The following is a description of a gene set: Human Gene Set: GSE14769_UNSTIM_VS_40MIN_LPS_BMDM_DN from publication Litvak V, Ramsey SA, Rust AG, Zak DE, Kennedy KA, Lampano AE, Nykter M, Shmulevich I, Aderem A (PMID 19270711) Genes down-regulated in comparison of unstimulated macrophage cells versus macrophage cells stimulated with LPS (TLR4 agonist) for 40 min. studied in species Homo sapiens The innate immune system is a two-edged sword; it is absolutely required for host defense against infection, but if left uncontrolled can trigger a plethora of inflammatory diseases. Here we used systems biology approaches to predict and validate a gene regulatory network involving a dynamic interplay between the transcription factors NF-κB, C/EBPδ, and ATF3 that controls inflammatory responses. We mathematically modeled transcriptional regulation of Il6 and Cebpd genes and experimentally validated the prediction that the combination of an initiator (NF-κB), an amplifier (C/EBPδ) and an attenuator (ATF3) forms a regulatory circuit that discriminates between transient and persistent Toll-like receptor 4-induced signals. Our results suggest a mechanism that enables the innate immune system to detect the duration of infection and to respond appropriately., and this is the list of marker genes: CTTNBP2NL, PIBF1, BIRC3, RNF19B, SLC4A1AP, SGK1, IFRD1, NSMCE1-DT, VEGFA, EXOC3L4, SYCE3, CSNK1E, ATPAF1, UBC, TOB1, ZFP62, SETDB2, TLR2, IL10RA, ZC3H12C, RND3, ATF3, MALT1, FILIP1L, LHCGR, DUSP1, IRF1, RMC1, TASL, TGIF1, RRAGA, CDC42EP2, KDM6B, JUNB, SLC38A2, SPATS2, MEX3C, RCAN1, PTPN5, NFKBIB, ARFGAP3, HAUS7, USP18, GPD1L, TRAF1, IER5, SQSTM1, EGR1, L3MBTL3, GK5, JUN, IL11RA, CD14, GAS8, PLK2, SDC4, STK35, ARID5A, CFLAR, KLKB1 (kallikrein B1), MMP13, CXCL2, PIM1, PHLPP2, NFKBID, MYC, PTGER4, FEM1C (NCBI Gene Id 84463), CEBPB, CCL2, CCRL2, MAFF, CCNL1, ERRFI1, CXCL3, SOWAHC, NFKBIA, SLAMF7, BLZF1, DUSP2, PDE4B, PROCR, RYBP, MCL1, NFKBIE, CCL7, CKS2, OSGIN2, HMGB2, ZFAND5, ACSL3, CDH11, CENPJ, FAM83D, SLC2A6, C3orf38, TNFAIP3, ATF2, ATL2, SIAH2, HILPDA, CLEC4E, CCDC71L, ODC1, DUSP5, DRD1, PNRC1, ST3GAL1, TLK2, TIPARP (NCBI Gene Id 25976), CHKA, SLC25A25, SOCS3, IL10, GPR84, NABP1, HSPA1A, VPS4A, CSRNP1, DNAJA2, RPS8, ALMS1, SMAD2, CCL4, FKBPL, EXT1, RELB, PHLDA1, BCL6, ID3, DNAJB4 (NCBI Gene Id 11080), ADTRP, ANLN, REL, CDK17, CITED2 (Cbp/p300 interacting transactivator with Glu/Asp rich carboxy-terminal domain 2), CD69, TLE4, MARCKSL1, OSM, ZFP36L1, ZC3H12A, TNFSF9, DUSP4, AOC3, S100PBP, TRIM13, PELI1 (pellino E3 ubiquitin protein ligase 1), HERPUD1, ZNF516, RNF103, GDF15, COQ9, TMEM177, CDKN2B, FAM72A, HLA-G, RGS1, IER3, GADD45B, SLFN12L, NFKBIZ, POC5, ID2 (NCBI Gene Id 3398), MED21, ARL5B, BCL9, MAPK8, TAF7, ADCK1, RAB20 (RAB20, member RAS oncogene family), ZFP36, CXCL10 (C-X-C motif chemokine ligand 10), NRROS, PLSCR1, LRIG2, CDH9, FANCL, PPP1R15A, MAP3K8, EHD1, FOS, POLB, TEX30, PTGS2 (NCBI Gene Id 5743), RPS6KA2, BTG2, SKIL, ETV3, BAG4, ZNF280B, KLF6, ZNF81, TNF, IER2, YRDC (NCBI Gene Id 79693), HSPA1B, RASGEF1B, CCL13, EGR2